The following is a description of a gene set: species: Homo sapiens Human Gene Set: GOBP_HEAT_GENERATION Any homeostatic process in which an organism produces heat, thereby raising its internal temperature., and this is the list of marker genes: PTGES, ARRDC3, TNF, ADRB2, TNFSF11, ABAT, TRPV1, IL1B, IL1A, APLN (apelin), EDNRB, ADRB3, NMU, SLC27A1, TNFRSF11A, HTR2A, ADRB1, PTGS2, PTGER3